Given this list of marker genes PHYH, ARHGAP42, GNAI1, BORCS7, COPS8, DISP1, FAM89A, ECI1, MCRIP2, SLC16A6, PAG1, RPS23, SDF2L1, TATDN3, TMEM64, FKBP11, here is a description of the gene set: studied in species Homo sapiens Human Gene Set: RODRIGUES_THYROID_CARCINOMA_UP Genes up-regulated in poorly differentiated thyroid carcinoma (PDTC) compared to anaplastic thyroid carcinoma (ATC). from publication Rodrigues RF, Roque L, Krug T, Leite V (PMID 17406368) Information on gene alterations associated to poorly differentiated (PDTC) and anaplastic thyroid carcinomas (ATC) is scarce. Using human cancer cell lines as a tool for gene discovery, we performed a cytogenetic and oligo-array analysis in five new cell lines derived from two PDTC and three ATC. In PDTC we evidenced, as important, the involvement of the MAPK/ERK kinase pathway, and downregulation of a group of suppressor genes that include E-cadherin. In ATC, downregulation of a specific group of oncosuppressor genes was also observed. Our ATC cell lines presented chromosomal markers of gene amplification, and we were able to identify for the first time the nature of the involved amplicon target genes. We found that the main molecular differences between the two cell line types were related to signal transduction pathways, cell adhesion and motility process. TaqMan experiments performed for five amplicon target genes and for two genes, which allowed a clear distinction between ATC and PDTC: CDH13 and PLAU corroborated array results, not only in the cell lines, but also in an additional set of primary 14 PDTC and three ATC. We suggest that our findings may represent new tools for the development of more effective therapies to the hitherto untreatable ATC.